The following is a description of a gene set: Any process that activates or increases the frequency, rate or extent of signal transduction mediated by the JNK cascade. species: Homo sapiens Human Gene Set: GOBP_POSITIVE_REGULATION_OF_JNK_CASCADE, and this is the list of marker genes: STK3, TIRAP, MAP3K5, CCR7, MAPK8IP3, RIPK1, DAB2IP, CCDC88C, CD27 (NCBI Gene Id 939), SERPINF2, XIAP, AXIN1, RNF13, TNFSF11, NR2C2, FZD7, CRACR2A (NCBI Gene Id 84766), MAP2K7, FGF19, TNFRSF11A, NRK (NCBI Gene Id 203447), TRAF6, AGER, DKK1, TLR3, FZD10, SH3RF2, MIR92A1, PJA2, PTK2B, IL1B, TNIK, CCL21, MAPKBP1, TAOK1, HMGB1, FCGR2B, CCN2, MINK1, MAP3K11, WNT16, TAOK2, NOD1, WNT5A, PYCARD, BIRC7, GADD45G, EPHA4, TRAF4, RIPK2, NOD2, DVL3, FLT4, MAPK8IP1, TAOK3, NAIP, MBIP, EDN1, HRAS, PLCB1, GADD45A, TLR9, TLR4, RASSF2, CCL19, MYOC, WNT7B (NCBI Gene Id 7477), RB1CC1 (NCBI Gene Id 9821), ANKRD6, APP, DUSP22, CARD9 (NCBI Gene Id 64170), MYD88, EDAR, SDCBP, SH3RF3, DUSP19 (dual specificity phosphatase 19), GADD45B, SLAMF1, UNC5CL, TPD52L1, NOX1, SH3RF1, MFHAS1, ZNF622, F2RL1, EDA2R, DVL2, MTURN, CRK, HIPK2, LTBR, MAP4K2, SEMA3A, MAP3K10, TNF, TNFRSF19, TRPV4, WNT7A